The following is a description of a gene set: studied in species Mus musculus Cytokines mediate cell-cell communication in the immune system and represent important therapeutic targets. A myriad of studies have highlighted their central role in immune function, yet we lack a global view of the cellular responses of each immune cell type to each cytokine. To address this gap, the authors created the Immune Dictionary, a compendium of single-cell transcriptomic profiles of more than 17 immune cell types in response to each of 86 cytokines (>1,400 cytokine-cell type combinations) in mouse lymph nodes in vivo. A cytokine-centric view of the dictionary revealed that most cytokines induce highly cell-type-specific responses. For example, the inflammatory cytokine interleukin-1β induces distinct gene programmes in almost every cell type. A cell-type-centric view of the dictionary identified more than 66 cytokine-driven cellular polarization states across immune cell types, including previously uncharacterized states such as an interleukin-18-induced polyfunctional natural killer cell state. from publication Cui A, Huang T, Li S, Ma A, Pérez JL, Sander C, Keskin DB, Wu CJ, Fraenkel E, Hacohen N (PMID 38057668) Genes positively differentially expressed in cell type: CD4+ T cell upon treatment with cytokine: IL-12 in mouse lymph nodes in vivo. Mouse Gene Set: CUI_T_CELL_CD4_IL12_RESPONSE_UP, and this is the list of marker genes: Parp9, Samhd1, Stat1, Irgm2, Mthfd2, Parp14, Ly6a, Psmb9, Psme1, Psme2, Gbp4, Tap2, Tapbpl, Socs1, Dtx3l, Psmb8, Gbp7, Irf9, Zbp1, Ifi203, Gbp8, Ly6e, Bst2, Tgtp2 (NCBI Gene Id 100039796), Tap1, Ppa1, Gbp2 (guanylate binding protein 2), Iigp1, Irgm1, Gimap4, Igtp, H2-T23, Psmb10, Ifi47, Irf1, Treml2, Vim